Given this list of marker genes Zfp36, Fos, Gadd45a, Atf3, Sec23a (NCBI Gene Id 217612), Ier2, G0s2, Lin9, Wwp2, Gsdme, H2ac21, Col15a1, Cdk4, Hsd11b1, Utf1, Sgk1, Dusp1, Ier3, Foxq1, Cct3, Cwc15, Plxna2, Pafah1b2, Wnt4, Timm8a1, Slc23a3, Vegfa, S100a1, Slc2a1, Jun, Slbp, Serpinb6a, Egr1, Zap70, Wdr74, Hnrnpll, Dnajc17, Adrb2, Ccdc186, here is a description of the gene set: Mouse Gene Set: RASHI_RESPONSE_TO_IONIZING_RADIATION_1 The ATM protein kinase, functionally missing in patients with the human genetic disorder ataxia-telangiectasia, is a master regulator of the cellular network induced by DNA double-strand breaks. The ATM gene is also frequently mutated in sporadic cancers of lymphoid origin. Here, we applied a functional genomics approach that combined gene expression profiling and computational promoter analysis to obtain global dissection of the transcriptional response to ionizing radiation in murine lymphoid tissue. Cluster analysis revealed a prominent pattern characterizing dozens of genes whose response to irradiation was Atm-dependent. Computational analysis identified significant enrichment of the binding site signatures of NF-kappaB and p53 among promoters of these genes, pointing to the major role of these two transcription factors in mediating the Atm-dependent transcriptional response in the irradiated lymphoid tissue. Examination of the response showed that pro- and antiapoptotic signals were simultaneously induced, with the proapoptotic pathway mediated by p53 targets, and the prosurvival pathway by NF-kappaB targets. These findings further elucidate the molecular network induced by IR, point to novel putative NF-kappaB targets, and suggest a mechanistic model for cellular balancing between pro- and antiapoptotic signals induced by IR in lymphoid tissues, which has implications for cancer management. The emerging model suggests that restoring the p53-mediated apoptotic arm while blocking the NF-kappaB-mediated prosurvival arm could effectively increase the radiosensitivity of lymphoid tumors. Cluster 1: ATM dependent genes induced at 30 min after ionizing radiation treatment. species: Mus musculus from publication Rashi-Elkeles S, Elkon R, Weizman N, Linhart C, Amariglio N, Sternberg G, Rechavi G, Barzilai A, Shamir R, Shiloh Y (PMID 16314843)